Given this list of marker genes Cryl1, Sord, Akr1a1, Dcxr, Xylb, here is a description of the gene set: Mouse Gene Set: REACTOME_FORMATION_OF_XYLULOSE_5_PHOSPHATE species: Mus musculus Formation of xylulose-5-phosphate